The following is a description of a gene set: species: Homo sapiens mRNA, protein, and metabolite inducation pathway by cyclosporin A Human Gene Set: WP_MRNA_PROTEIN_AND_METABOLITE_INDUCATION_PATHWAY_BY_CYCLOSPORIN_A, and this is the list of marker genes: ATF4 (activating transcription factor 4), NFE2L2 (NFE2 like bZIP transcription factor 2), SLC7A11, SLC1A5, SLC7A5, SLC3A2, KEAP1 (NCBI Gene Id 9817)